The following is a description of a gene set: studied in species Mus musculus A protein ubiquitination process in which a polymer of ubiquitin, formed by linkages between lysine residues at position 63 of the ubiquitin monomers, is added to a protein. K63-linked ubiquitination does not target the substrate protein for degradation, but is involved in several pathways, notably as a signal to promote error-free DNA postreplication repair. Mouse Gene Set: GOBP_PROTEIN_K63_LINKED_UBIQUITINATION, and this is the list of marker genes: Traf3ip2, Ube2s, Arih2, Prkn, Trim30c, Trim56, Sash1, Trim30d, Rnf167, Rnf4, Traf6, Ube2v2, Peli1, Rnf8, Birc2, Ptpn22, Rnf168, Trim12a, Ube2g1, Wwp2 (WW domain containing E3 ubiquitin protein ligase 2), Kcmf1 (NCBI Gene Id 74287), Peli3, Zfp598, Trim30a (tripartite motif-containing 30A), Rnf135, Ube2n, Rnf213, Zfp91, Bfar (bifunctional apoptosis regulator), Rnf152, Traf2, Cdkn2a, Pnkp, Ube2b, Ube2d2b, D1Pas1, Rnf5, Ripk2, Trim12c, Ube2v1, Ube2e2, Arrdc4, Ube2e3, Ddx3x, Ubr2, Itch, Parp10, Trim31, Trim21, Trim65, Ube2t, Trim3, Trim27, Aktip, Nedd4, Skp2, Rnf126, Smurf1, Stub1, Ube2srt, Rnf186, Plaa, Xiap, Rnf115, Fbxw7, Cep63, Magel2, Trim30b, Gps2, Hectd1, Trim8, Trim5, Trim32, Ube2o, Nod2, Prpf19